Given this list of marker genes DEGS1, PEDS1, FADS1, FADS2, SCD, FADS6, DEGS2, FADS2B, SCD5, SC5D, FADS3, here is a description of the gene set: Human Gene Set: GOMF_OXIDOREDUCTASE_ACTIVITY_ACTING_ON_PAIRED_DONORS_WITH_OXIDATION_OF_A_PAIR_OF_DONORS_RESULTING_IN_THE_REDUCTION_OF_MOLECULAR_OXYGEN_TO_TWO_MOLECULES_OF_WATER Catalysis of an oxidation-reduction (redox) reaction in which hydrogen or electrons are transferred from each of two donors, and molecular oxygen is reduced to two molecules of water. studied in species Homo sapiens